The following is a description of a gene set: Mouse Gene Set: GOBP_CEREBELLAR_NEURON_DEVELOPMENT species: Mus musculus The process whose specific outcome is the progression of a cerebellar neuron over time, from initial commitment of the cell to a specific fate, to the fully functional differentiated cell., and this is the list of marker genes: Nanos1, Samd4b, Crkl, Crk, L1cam (L1 cell adhesion molecule)